The following is a description of a gene set: studied in species Mus musculus This event has been computationally inferred from an event that has been demonstrated in another species.<p>The inference is based on the homology mapping from PANTHER. Briefly, reactions for which all involved PhysicalEntities (in input, output and catalyst) have a mapped orthologue/paralogue (for complexes at least 75% of components must have a mapping) are inferred to the other species. part of: Ion channel transport electronically inferred by orthology from the curated human pathway Reactome Pathway: Ion transport by P-type ATPases, and this is the list of marker genes: Fxyd2, Atp2b4, Atp1b2, Atp12a, Atp8b2, Atp1b1, Atp11b, Camk2b, Atp13a5 (ATPase type 13A5), Atp2b1, Atp8a1, Atp8b1, Pln, Atp2a3, Atp1b3, Atp9a, Atp2a1, Atp2c2, Atp7b, Fxyd3, Atp2b3, Pdzd11, Calm1, Atp13a1, Atp1a3, Atp13a2, Atp9b, Atp4b, Atp4a, Atp1a2, Atp8a2